Given this list of marker genes Knl1, Pkmyt1, Mos, Zwint, Chfr, Stk35, Ttk, Pdik1l, Ovol1, here is a description of the gene set: Any process that stops, prevents or reduces the frequency, rate or extent of meiotic cell cycle phase transition. studied in species Mus musculus Mouse Gene Set: GOBP_NEGATIVE_REGULATION_OF_MEIOTIC_CELL_CYCLE_PHASE_TRANSITION